Given this list of marker genes Fbln5, Lrrfip1, Celf4, Acin1, Nicol1, Nr1d2, Skil, Slfn1, Wnt10b, Wnt4, Slfn2, Sox7, Bmp4, Pax6, Hnrnpl (heterogeneous nuclear ribonucleoprotein L), Jund, Axin1, Mtdh, Nfix, Mzf1, Myt1l, Psmd10, Fzd1, Purb, Elf2, Ascl3, H1f3, Cc2d1a, Lmo1, Zbtb34, St18, Hmx1, Rsl1, Oog2, Dusp22, Zfp24, Runx1, Pcgf2, Hmgb1, Ptpn2, Sap30, Sox11, Ahr, Sap25, Paf1, Atn1, Kdm1a, Arid4a, Mapk10 (NCBI Gene Id 319641), Niban2, Apbb1 (NCBI Gene Id 11785), Zbtb1, Mup11, Tfec, Ctnnb1, Zfp958, Six4, Zfp809 (zinc finger protein 809), Hsbp1l1, Msc, Brd7, Cited1, Ighmbp2, Cby1 (chibby family member 1, beta catenin antagonist), Loxl3, Zbtb33, Nfatc4, Uimc1, Zfp819, Meioc, Nbas, Boll, Smarca5, Rbbp4, Zbtb7a, Kctd15, Sox2, Cnot2, Hbp1 (high mobility group box transcription factor 1), Fcor, Id2, Gli2, Pax5, Nr2f2, Mlip, Notch2, Trp63, Nab1, Nfx1, Actr6, Ilf3, Eno1, Hipk2, Foxn3, Sox12, Pitx1, Tgfbr1, Csf2, Bcl6, Mdm2, Pias1, Tbx22, Phb2, Mospd1, Prdm14, Arid5a, Ferd3l, Atf2, Map3k10, Zfp296, Batf3, Mbtd1, Bin1, Ascl2, Nudt16, Thra, Trpv4, Nkx3-1, Atf3, Zfp202, Stat6, Maz (MYC-associated zinc finger protein (purine-binding transcription factor)), Mdm4, Zfp683, Cirbp, Gata3, Ikzf1, Qki (NCBI Gene Id 66145), Nscme3l, Hjv (hemojuvelin BMP co-receptor), Hdgf, Ehmt1, Arid1a, Sinhcaf, Ift172, Cxxc5, Pml, Dab2, Cenpf, Tent5b, Ins2, Pawr, Ajuba, Epc1, Nipbl, Bag4, Cebpb, Foxh1, Hnf4a, Zbtb42, Jph2, Men1, Bcl11a, Scai, Asxl2, Rfx3, Nelfcd (NCBI Gene Id 96962), Nr4a2, Zkscan3, Tle4, Rbm42, Magea8, Wwc1, Zscan10, Foxk2, Ifi207, Sox4, Qars1, U2af2, Flna, Wdr5, Sp100, Tfcp2l1, Sall1, Depdc1a, Skor1, Six3, Nmnat1, Mbip, Parp9, Dlx4, Pfdn5, Amotl2, Ncoa2, Pou3f3, Esx1, Nrip1, Max, Heyl, Lyar, Jarid2, Pias4, E2f8, Birc5, Morc3, Tbx20, Impact, Hexim1, Ctbp1, Sox5, Magee2, Bmyc, Bend6, Mageb3, Zglp1 (zinc finger, GATA-like protein 1), Cryab, Zbtb7b, Elane, Gmnn, Osr1, Nkrf, Klf3 (Kruppel-like transcription factor 3 (basic)), Ccar1, Trpv1, Mphosph8, Cdk2, Scrt1, Wdr82, Setdb2, Scml2, Rbm15, Hoxc8, Arid5b, Rbbp8, Nanog, Sfmbt1, Zc3h14, Esrrb, Zbtb14, Trim6, Limd1, Rrp8, Plk1, Cbx5 (chromobox 5), Zfp57, Nr3c1, Sumo2, Smad7, Tbx2, Supt4a (NCBI Gene Id 20922), Runx1t1, Pcbp4, Ciita, Bend3, Gatad2b, Cd38, Dll4, Tagln3, Sirt7, Kdm4a, Rbfox2, Dlx1, Med25, Suv39h2, Hspa8, Grem1, Ylpm1, Tcf25, Ar, Casp8ap2, Hoxa2, Id4, Sdcbp, Shh, Strn3, Rbm47, Etv6, Rorc, Etv3, Irf8, Ccnd3, Il17a, Esr2, Ing2, Cd36 (NCBI Gene Id 12491), Mynn, Eng, Pwp1, Fbxw11, Mapk15, Larp4b, Tent4b, Sars1, Kdm2b, Cbfa2t3, Nkx3-2, Hes1, Fxr1, Ccnd1, Klf8, Dap, Morc1, Scgb1a1, Kdm5a, Zfp13, Nkx6-2, Mypop, Spdef, Rbm20, Foxp2, Tfdp2, Sin3b, Yaf2, Prdm16 (PR domain containing 16), Runx3, Tbr1, Zfp125, Mageh1, Znhit1, Crebbp (NCBI Gene Id 547230), Traf6, Taf15, Pole3, Foxk1, Sfmbt2, Nfatc3, Tle6, Snx6, Bach2, Tent5d, Lilrb4b, Irx3 (NCBI Gene Id 16373), Nog, Gtf2ird1 (general transcription factor II I repeat domain-containing 1), Mageb16, Dedd, Mettl1, Klf16, Timeless, Trp53, Nr1h2, Ring1, Smyd1, Id3, Smad3 (SMAD family member 3), Foxd3, Shc1, Brms1l (breast cancer metastasis-suppressor 1-like), Tsc22d4, Tro, Rcor1, Rbm15b, Xpo1, Irx4, Nop53, Lrpprc, Eid2, Dyrk1a, Eed, Sgms1os1, Rasd1, Gon4l, Ifi213, Trerf1, Insm2, Pax9, Alx1, Commd7, Ascl1, Ptprc, Ddit3, Phf19, Wwc2, Tirap, Mbd3l1, Nr1h3, Mier3, Srebf2, Sox14, Sirt2 (sirtuin 2), Mepce, Zfp354a, Hnf1a, Fabp4, Mapkapk2, Zc3h8, Ctr9, Zfp148, Zfp423, Gata2, Sin3a, Jazf1, Phb1, Magea2, Phc3, Zfp541, Ovol2, Nsmce3, Ctcf, Hmbox1, Gata1, Isl1, Riox1, Zfp932, L3mbtl2, Apobec1, Mybbp1a, Prmt2, Dhx36, Foxr1, Irf2bpl, Vdr, Irak1, Pparg, Nostrin, Elf3, Btrc, Dnajb5, A1cf, Smad4, Zfp473, Hdac1, Mecom, Twist1, Kat6a, Sox3, Twist2, Sox10, Atp8b1, Zfp131, Ybx2, Hbb-y, Zmym5 (NCBI Gene Id 219105), Kat8, Foxo3, Setd5, Sox8 (SRY (sex determining region Y)-box 8), Foxa1, Rnf2, Tasor, Tle5, Nkx2-1, Vax1, Nab2, Prkn, E2f7, Gdnf, Traf3ip2, Wfs1, Dnaja3, Foxs1, Bmp7, Clock, Pcna, Phf12, Atxn1l, Helt (helt bHLH transcription factor), Hcls1, Hes7, Dact1, Igf2bp3, Tenm2 (teneurin transmembrane protein 2), Ahrr (aryl-hydrocarbon receptor repressor), Lbh, Kmt5a, Glis1, Hdac3, Nfic, Cpeb3, Samd1 (sterile alpha motif domain containing 1), Zfp706, Tshz3, Hes2, Larp1, Fezf2, Bach1, Wdtc1, Zmynd15, Prrx1, Ywhaq-ps3, Tent5c, Foxe1, Sox13, Fgfr2, Ifng, Bap1, Ywhaz, Rhox3a, Otp, Rreb1, Pkia (protein kinase inhibitor, alpha), Snai1, Dnmt3a, Mlx, Dlg1, Bmp6, Irf2bp1, Kat2b, Apbb3, Hivep1, Dab2ip, Pasd1, Nkx6-1, Snai3, Halr1, Rbm38, Nr1d1, Nelfe, Trim37, Crebzf, Smad5, Upf3a, Coq7, Zfp111, Scml4, Zc3h6, Wwp2, Suz12, Efna1, Oog3, Pabpc1, Parn, Scx, Sim2, Isx, E2f1, Mir7-1, Ddx5, Nr1h4, Sp3, Nacc1, Zfp653, Bhlhe41, Larp7, Fgfr3, Dnajb4, Hsf5, Id1, Zfp1006, Zfp488, Dmrt1 (doublesex and mab-3 related transcription factor 1), Tbx15, Il4, Cry2, Zgpat, Hes3, Cbx1, Lhx1, Cdk5r1, Nfib, Daxx, Tfap2a, Prmt6, Satb1, Irf2bp2 (NCBI Gene Id 672960), Hes5, Pax2, Hand1, En1, Prdm8, Gata6, Ing4, Yeats2, Elk4, Rbm24, Apbb2, Ptprk, Loxl2, Mef2a, Zcchc17, Rarb, Chd8, Msx1, Zfp175, Magea14, Zeb2, Csde1, Cic, Gli3, L3mbtl3, Maged2, Pcbp3, T, Foxc1, Mxd1, Tcerg1, Rps14, Tnf, Tbx6, E2f6, Map2k5, Zbtb39 (zinc finger and BTB domain containing 39), E4f1, Zbtb32, Egr1, Rbbp7, S100a1, Hmgn2, Zfp973, Psen2, Smarca4, Sox9, Tnfsf4, Uri1, Maf, Ski, Ankrd1, Relb, Zbtb20, Cbx6, Foxp3, Tcf7, Zbtb16, Plk3, Smyd2, Mageb5b, Npas1, Six1, Cry1, Tle2, Magea10, Sap30l, Fezf1, Il1b, Klf11, Cux1 (cut-like homeobox 1), Prickle1, Mier2, Ppid, Dicer1, Elavl1, Sall2, Ldb2, Hnf1b, Cbfa2t2, Akr1c6, Magea13, Magea5, Tfap2b, Pspc1, Ikzf4, Sox15, Wwp1, Zbtb6, Tob1, Nrg1, Zfp397, Tcp10c, Cebpd, Dach1, Ikbke, Zbtb45, Prkaca, Glis3, C1qbp, Olig3, Rorb, Nr6a1, Samd7, Barx2, Dhrs7b, Smarca2, Nrde2, Mup2, Hmga2, Msx3, Sema4d (NCBI Gene Id 20354), Kat2a, Rtf1, Yy1, Foxc2, Eid2b, Rlim, Bend5, Nfil3, Ern2, Hoxb3, Foxj1, Traf2, Zbtb2 (zinc finger and BTB domain containing 2), Ankrd2, Dnmt3b, Ppara, Tal1, Rpl10, Zfp512b, Npm1, Cops2 (NCBI Gene Id 98909), Trim27, H3c14, Hr (lysine demethylase and nuclear receptor corepressor), Dr1, Nfe2l3, Hinfp, Pphln1, Zfp715, Hnrnpab, Trim66, Lmcd1, Atf5, Tet1, Zbtb4, Syncrip, Zfp239, Tgfb1, Nkx2-5, Ppm1f, Hey1, Zar1, Thap11, Actrt1, Scaf4, Hipk3, Dkc1, Glrp1, Mecp2, Mageb11, Pura, Jdp2, Nr0b2, Kat5, Hic1 (hypermethylated in cancer 1), Rarg, Cc2d1b, Prdm6, Zbtb46, Dmap1, Fam76b, Irx1, Suds3, Btaf1, Notch4, Rb1, Hdac7, Lims1, Bptf, Calr, Ezr, Dazl, Rif1, Ralgapa1, Cbx3, Lef1, Eno1b, Suv39h1, Tbx1, Magea6, Khdrbs1, Cdx2, Cmtm2a, Hdac4, Hopx, Hif1a, Ptgs2os, Aebp1, Mbd1, Glis2, Sox6, Zfp748, Hoxb13, Fbp1, Mtor, Snw1, Zfp438, Strap, Igf2, Mta1, Tcfl5, Tfap4, Spindoc, Kdm5b (NCBI Gene Id 98723), Neurog3, Myc, Spen, Hsbp1, Tbx18, Nepn, Nr1i3, Zfp90, Plcb1, Ndufa13, Magea4, Rhox2a, Deaf1, Tbx3, Mterf3, Atf4, 5730507C01Rik, Tmprss6, Mta3, Tgif2 (NCBI Gene Id 97009), Pde2a, Zc3h4, Hif1an, Zic2, Zmynd11, Rnf8, Xrcc6, Hesx1, Myef2, Zfp692, Otud7b, Ppp1r15a, Zbtb37, Morc2b, Mageb18, Rgn, Mafk, Pou3f1 (NCBI Gene Id 18991), Rbl1, Vgll4, Tcp10b, Hes6, Srebf1, H1f5, Vhl (von Hippel-Lindau tumor suppressor), Gabpa, Baz2a, Psen1, Tcf3, Ereg, Skor2, Nelfa (negative elongation factor complex member A, Whsc2), Tpr, Foxl2, Hdac9, Nsd1 (NCBI Gene Id 18193), Ppp1r13l, Rsf1, Zfp281, Myoz2, Creb3l1, C1d, Ywhab, Srsf7, Atf7, Nfkb1, Dnajc17, Zfp639, Rbm10 (NCBI Gene Id 260306), Zfp3 (zinc finger protein 3), Scrt2, Igf2bp2, Tnp1, Trps1, Pias3, Zfp366, Usp2 (NCBI Gene Id 53811), Tcf23, Pbxip1 (pre B cell leukemia transcription factor interacting protein 1), Rcor2, Cdk5, Nck2, Tle1, Dnajb1, Ogt, Crebrf, Zbtb49, Paip1, Wtip, Olig2, Usp47, Gm4275, Hnrnpk, Srf, Nedd4, Zfp777, Mir466l, Cdx4, Hmgb2, Ifi208, Tada3, Drd3, Gadd45a, Nfatc1 (nuclear factor of activated T cells, cytoplasmic, calcineurin dependent 1), Rnps1, Foxp4, Pramel1 (NCBI Gene Id 83491), Macroh2a1, Tgif1, Prdm13, Zp3 (zona pellucida glycoprotein 3), Edn1, Nkx6-3, Larp7-ps, Gata5, Zfp12, Wnt11, Smarcc2, Brms1 (breast cancer metastasis-suppressor 1), Foxg1, Met, Pramel7, Taf9b, Nfkbie, Setmar, Sdr16c5, Zfhx3, Sox30, Myf6, Ednrb, Nr2c2, Zbtb10, Dmbx1, Magea9, Prox1, Hipk1, Klf4, Sfrp2, Sla2, Foxd1, Sry, Sumo1, Mbd3l2, Zfp318 (zinc finger protein 318), Tcp10a, Dnd1, Msx2, Zfp746, Hoxb8, Slc11a1, Hnrnpc, Lpin1, Flywch1, Ripply3, Wt1, Maged1, Mup1, Mxd4 (NCBI Gene Id 69247), Sap18, Wnt5a, Nodal, Pou5f1 (NCBI Gene Id 18999), Aicda, Foxf1 (NCBI Gene Id 15227), Txnip (NCBI Gene Id 99524), Secisbp2 (NCBI Gene Id 75420), Supt4b, Uhrf1, Dkk3, Sox18 (NCBI Gene Id 98938), Pax3, Dnajb6, Npat, Kat6b, Zbtb18, Mdfic2, Pou1f1, Mbd2, Gsc, Irf1, Xbp1, Notch1, Bmal1, Rpl23, Naf1, Frk, Ago2, Tdg, Pou2f1, Sbno2, Acvr2b, Tcf21, Bcorl1, Ripply1, Scmh1, Ppard, Rpl10-ps3, Ifi209, Samd11, Magea1, Trim29, Zfp219, Hhex, Uba3, Rps6ka5, Foxq1, Psmc5, Bcor, Hmg20a, Six5, Hnf4aos, Ezh1, Crym, Tcf4, Ets2, Dusp26, Hnrnpa0, Nelfb, Ifi214, Mideas (mitotic deacetylase associated SANT domain protein), Tnfsf11, Sgf29, Thap7, Flcn, Brca1, Uxt, Gfi1, Crem, Rhox5, Zbtb38, Zfp418, Zfp386, Klf2, Mlxipl, Aurkb, Hoxa7, Irx2, Cav1 (caveolin 1, caveolae protein), L3mbtl1, Cbx2, Nck1, Dusp15, Bahd1, Klf17, Rnf168, Ikzf5, Trim24, Tent4a, Jun, Nif3l1, Ddx20, Pkp1, Mageb5, Zfp451, Zfp616, Ifi27, Srsf9, Per2, Sfn, Sap130, Sp5, Tcf7l2, Zfp568, Pdgfb, Phax, Gps2 (NCBI Gene Id 56310), Eomes, Sfpq, Noc2l, Nfkbia, Sfswap, Prdm11, Mettl13, Ccar2, Tbx21, Cipc, Ybx3, Satb2, Phf6, Epas1, Prdm2, Cebpa, Trim28, Smo, Sirt6, Rxra, Gm4924 (NCBI Gene Id 237412), Mdfi, Sox21, Oog1, Macroh2a2, Zfp608, App, Foxf2, Thrap3, Gatad2a, Ep300, Ncor2, Inpp5k, Zfp174, Kdm8, Cbx4, Cnbp, Trdmt1 (NCBI Gene Id 13434), Rbpj, Parp1, Zfp735, Src, Elk3, Zbed6, Apobec3, Myocd, Zfta, Vsx2, Phc2, Zfp536, Zfp36, Ruvbl2, Fus, Cdkn2a, Fnip2 (folliculin interacting protein 2), Chd4, Mup4, Pcgf1, Srsf4, Scaf8, Mitf, Rbmxl1, Prdm12, Fasl, Zfp827, Pdx1, N4bp2l2, Bmi1, Tent2, Magee1, Nr4a3, Hba-x, Fnip1, Dubr, Cdkn1c, Eapp (E2F-associated phosphoprotein), Nkap, Ciart, Cdyl, Ptbp1, Bhlhe40, Nr2e3, Zfp658, Yap1, Rara, Mier1, Mup5, Basp1, Magea3, Tbl1xr1, Akirin2, Bclaf1, Ppargc1b, Ccdc85b, Lep, Phf21a, Shox2, Atoh8, Zfp750, Cir1, Il33, Traf3ip1, Notch3, Amot, Spi1, Ehmt2, Trib3, Aebp2, Lefty1, Dnmt3l, Sp2, Nfe2l1, Insm1, Nr2c1, Ovol1, Mageb4, Raly, Ncor1, Xrcc5, Mesp1, Foxo1, Prnp, Ripply2, Sarnp, Arid4b, Prop1, Zbtb24, Dlx2, Hoxb4, Noct, Pitx2, Tnfrsf4, Wwtr1, Tbl1x, Pax4, Pkig, Mkx, Osr2, Esr1, Pcgf6, Sfrp1, Ctnnbip1, Tsg101, Sirt1, Fhl2, Mta2, Setdb1, Hnrnpu, Klf7, Kdm2a, Rcor3, Zeb1, Zfp382 (NCBI Gene Id 73854), Hdac2, H1f4, Pou4f2, Hoxd9 (homeobox D9), Vegfa, Phc1, Foxm1, Klf10, Elavl4, Pex14, Mettl14, Hmga1b, Riox2, Txn1, Irx6 (Iroquois homeobox 6), Srsf1, Hexim2, Med1, Klf5, Gas6, Sufu, Smarce1, Ccne1 (cyclin E1), Mxi1, Myb, Tceal7, H1f2, Mbd3, Mef2c, Rest, Ifi203-ps, Dusp5, Mael, Gclc, Xcl1, Srsf10, Per3, Nsd2, Esrra (NCBI Gene Id 269047), Prdm5, Zmym2, Tardbp, Sorbs3, Bmp2, Smad2, Per1, Zfp469, Rere, Zfp128, Nr1h5, Nr2f6, Magel2, Mettl16, Hspa1a, Pkp3, Zfp354c, Mad2l2, Cul3, Zfp263, Nr2f1, Hcfc1, Fam220a, Mnx1, Bcl3, Phf14, Zbtb26, Thap1, Hoxd8, Bcl6b, Supt5, Capn3, Hey2, Sqstm1, Zfp703, Lmo4, Ddx54 (DEAD box helicase 54), Tsix, Ctbp2, Vip, Atxn1, Rfx5, Smtnl1, Rfc1, Stat1, Zfp217, Mcph1, Cnot1, Hnrnpa2b1, Cdk6, Ybx1, Ube2i, Sox1, Fgf9, Tcf7l1, Kctd1, Btg2, Epo, Zfp668, Cbfb (NCBI Gene Id 12400), Hdac10, Cbx8, Zhx1, Tmbim6, Traf5, Lancl2, Recql5, Eid1, Ldb1, Ptbp3, Ndn, Cggbp1, Hcfc2, Lhx9, Gzf1, Taf3, Prmt5, Mageb6b1, Ifi206, Nsd3, Igf2bp1, Sap18b (NCBI Gene Id 100041953), Zbtb12, Myoz1, Pa2g4, Srsf6, L3mbtl4, Chd3, Pou4f1, Mageb2, Prdm1, Kcnip3, Zmynd8, Trim11, Arx, Dkk1, Zhx2, Lilrb4a, Hamp, Zfp503, Ezh2, Ywhaq, Zfpm2, Kdm5c, Fgfr1, Nacc2, Usp3, Traf7, Kat14, Thrb, Axin2, Rbm46 (NCBI Gene Id 633285), Lcor, Ptch1, Magec2, Nrarp, Drap1, Dcaf1, Nr1i2, Dnmt1, Kank2, Nfatc2, Prdx5, Hbb-bh1, Cited2, Tent5a, Sall4, Angel2, Hsf4, Creb1, Zbtb21, Zfpm1, Zbtb25, Vax2, Patz1, Zhx3, Slirp, Gata4, Foxa2, Runx2, Myd88, Hdac5, Mdfic, Cela1, Hnrnpd, Nupr2, Dhx9, Cux2, Cdc73, Adipoq, Pou6f1, Nsun2, Maf1, Hmga1, Cdkn1b, Zfp354b, Foxp1, Nono, Mndal, Morc2a, Mnt, Zbtb5 (zinc finger and BTB domain containing 5), Sik1, Mxd3, Spop, Nrip2, Cbx7 (NCBI Gene Id 69793), Zbtb8a (zinc finger and BTB domain containing 8a), Fst, Eif4enif1, Taf7, Rela, Ascl5, Lin37, Peg3, Muc1, Chd5, Nr2e1, Atf7ip, Cys1, Rybp, Klf12, Nr0b1, Mup3, A430033K04Rik, Bhlhe22, Cnot7, Dhx34, Keap1, Ifi203, Snai2, Ing1, Pdcd4, Hsf1, Mmp12, Gbp4, here is a description of the gene set: Any process that stops, prevents, or reduces the frequency, rate or extent of the chemical reactions and pathways involving RNA. species: Mus musculus Mouse Gene Set: GOBP_NEGATIVE_REGULATION_OF_RNA_METABOLIC_PROCESS